The following is a description of a gene set: Assembly of actin filament bundles in which the filaments are tightly packed (approximately 10-20 nm apart) and oriented with the same polarity. studied in species Mus musculus Mouse Gene Set: GOBP_PARALLEL_ACTIN_FILAMENT_BUNDLE_ASSEMBLY, and this is the list of marker genes: Fmn2, Aif1, Spire2, Spire1, Ush1c, Espn, Fscn1